Given this list of marker genes NPR2, KIF15 (NCBI Gene Id 56992), GDF5, RAC1, NGLY1, here is a description of the gene set: Human Gene Set: HP_ACROMESOMELIA studied in species Homo sapiens Small hands and feet. Acromesomelia